Given this list of marker genes Nrg1, Npvf, Inhba, Runx1, Foxl2, Mfn2, Crhr1, Gnas, Cry2, Inha, Ren1, F2r, Inhbb, Gja5, Tacr2, Tspo, Pomc (pro-opiomelanocortin-alpha), C1qtnf1, Fgfr4, Lif, Agtr1a, Retn, Gja1, F2rl1, Acvr2a, Cyp27b1, Ghrl, Pex5l, Cyp19a1, Bmp6, Tac1, Rab8b, Crhr2, Gal, Kiss1, Ecrg4, Kdm5b, Fgfr1, Ucn (urocortin), Galr1, Nkx3-1, Spp1, Ucn2, Dab2, Smad4, Kcnk9, Agt, Vdr, Crhbp, Or51e2, Crh, Agtr2, Gdf9, Kcnn4, Oprk1, Lep, Apln, Ptpn11, Cyp2j5, Cry1, Oprm1, here is a description of the gene set: species: Mus musculus Mouse Gene Set: GOBP_REGULATION_OF_ENDOCRINE_PROCESS Any process that modulates the frequency, rate or extent of an endocrine process, a process involving the secretion of or response to endocrine hormones. An endocrine hormone is a hormone released into the circulatory system.